The following is a description of a gene set: species: Homo sapiens Human Gene Set: GOBP_CENTRAL_NERVOUS_SYSTEM_DEVELOPMENT The process whose specific outcome is the progression of the central nervous system over time, from its formation to the mature structure. The central nervous system is the core nervous system that serves an integrating and coordinating function. In vertebrates it consists of the brain and spinal cord. In those invertebrates with a central nervous system it typically consists of a brain, cerebral ganglia and a nerve cord., and this is the list of marker genes: COL4A1, KCNC2, ABCB1, TP53, IMMP2L, NEUROD6, NKX6-2, MACO1, HSPG2, UCHL5, CXCL12, JRKL, PIAS4, VPS13B, ATIC, WDR1, P2RY12, NOTO, ATM, BRSK2, KIFBP, NOTCH1, PITX1, HIF1A, RRM1, MAPK1, KCNJ10, DHX37, HOOK3 (hook microtubule tethering protein 3), HPCAL4, ARL13B, BCAN, TCTN1, PADI2, CDK5R2, CDC42, EPHA5, NRG3, RBBP7, MGARP, VPS51, ODAD3, GPX4, PSEN1, FEZF2, KCNA1, VCX3A, MYRF, IL6ST, TBX20, NDNF, RAB18, FBXO41, HOXB1, HAPLN4, APP, PTCHD1, EED, PTPRJ, NR4A3, VPS54, GHRH, IFT122, RARA, SFRP2, ATG16L1, PTF1A, GLUD1, GPR37L1, GSN, SFRP1, BRINP2, ABAT, IL1RAPL2, TBR1, MARCKSL1, PLXNA1, CIC, BCL2, NOG, HTR6, HMX2, RECK, SKI, DAB1, BMPR1A (bone morphogenetic protein receptor type 1A), SRGAP2, VCAN, DPCD, PAX8, TAGLN3, EXT1, MEIS3P1, STK4, CD9, WDR89, FILIP1, SLC8A3, NKX2-1, CUL4B, ATRX, DCT, YWHAH, SEMA3F, BCL11B, BARHL2, FOXO3, GLI3, MCPH1, JHY, ERCC2, TUBB2B, EEF1AKMT4-ECE2, CWH43, C21orf91, LHX1, WNT4, SELENOP (selenoprotein P), SMO (NCBI Gene Id 6608), CASP3, CLUAP1, CASP5, EIF2B3, FGF13, ALDH1A3 (NCBI Gene Id 90476), VTN, ZEB1, ZIC4, ASPM (NCBI Gene Id 93990), SLC38A2, LHX5, NUMB, EIF2B4, SSTR1, RORB, CREB1, PRKG1, ISL2, ATP1A2, GRIN2B, ACTL6A, HAPLN2, FXR1, CEND1, SEMA6B, KDM1A, NRP1, GCM1, DRGX, SLC1A1, GPM6B, NEUROD4, IGF2BP1, INTU, SLIT3, CEP120, NTRK2, STAT3, S1PR1, TFAP2D, SUDS3, PALS1, JARID2, SIRT2, TMEM108, PRKCA, RAB3GAP1, GSC, MDGA1, GSX2, ARNT2, TOP2B, C12orf57 (NCBI Gene Id 113246), PAX2, EIF2B5, GLI1, CERS5, MAL, SLC6A3, DHX30, EPHB1, GRIK1, TPP1, FKRP, NCSTN, YWHAQ, TACC1, TBX19, DNAAF3, CHRNB2, PRKDC, GRIN1, WNT5A, NHEJ1, WWP1, SH3GL1, AKT3, NEUROG1, KCNE1, NME7, FOXG1, CDK5R1, LDLR, B2M, ARX, SPHK1, WDR37, KIF14, NDEL1, ADGRG6, SDF4, KIAA0319, RAC3, NLGN4X (NCBI Gene Id 64642), SLC25A46, STXBP3, ERBB4, LHX4 (LIM homeobox 4), LAMB2, ALDH1A2, TSPAN2, CNTN4, UQCRQ, ATN1, MAG, SEC16A, BAG3, ZIC2, CHST8, MEIS2, IRS2, ROBO2 (roundabout guidance receptor 2), FGF9, MDGA2, QKI, BMP2, TACC2, NSUN5, RAN, LIF, RFX4, SALL1, ZNF148, SOX4, SLC32A1, MIR26A1, LONRF2, ID2, PTBP2, NCAN, CNTF, CTNS (NCBI Gene Id 1497), PTCH1, FUT1, FOXB1, ISL1, NME5, BMP5, GRIA1, LHX8, PHOX2B, NKX2-6, NOVA2, BTD, TBX1, TAF1, FGFR1, POMGNT1, SYNE2, MYO16, TYROBP, PRKN, VPS4B, NDRG2, PHOX2A, BTG2, SLC2A1, CBLN1, GRID2, MAPKAP1, VIM, LRP6, FRS2, STK3, ITGB1, TP73, BBS1, EFHC1, TSKU, DAG1, CSNK2A2 (casein kinase 2 alpha 2), ZEB2, LMX1A, FGF10, OLIG1, CYP26B1, CALM2, COL3A1 (collagen type III alpha 1 chain), SLC6A4 (solute carrier family 6 member 4), COL2A1, EMX2, ATP5PF, POU6F1, SIX1 (NCBI Gene Id 6495), NPAS2, UFC1, SPTBN2, AIM2, CFL1, WNT7B, PTPN11, STIL, VIT, MYCN, HOXD10, LHX2, TMX2, LIG4, SOX1, FGF8, UGT8, SHANK3 (NCBI Gene Id 85358), PLXNB2 (plexin B2), MAOB, MAFB, DLG5, WNT7A, SUN2, DCX, KCNC1 (NCBI Gene Id 3746), DNAJC30, PTN, HOXA2 (homeobox A2), WDR62, BAG6, SOX13, ADARB1, GSX1, POU1F1, TREM2, ANP32B, OPHN1, DLX1, GBA1, CFAP43, APAF1, LMO4, CDK20, S100A1, MEIS1, LAMB1, CLN8, GRIN2D, NEFL, WNT9B, TRAPPC9, BMERB1, POU4F2, MDK, BIN1, ABCB6, EGFR, ERBB2, DKK1, SCN5A, FCGR2B, SEMA6D, PLXDC1, AGTPBP1, GPR158, CA10, RTN4RL1, CSF1R, LEF1, NNAT, FZD3, CCDC134, BMP7, AKNA, ZNF430, SNTG2, SMARCA1, NANOS1, RHEB, LAMC3, TOX, HOXB2, SOX2, WNT3A, NOTCH2NLA, TGIF1 (NCBI Gene Id 91941), SOS1, TULP3 (TUB like protein 3), ATF2, VAX2, HESX1, DCLK2, C5AR1, SH3GL3, ATRN, AARS1, FUT10, SPTBN4, ACAN, NRG1, GPR17, ACTB, NES, TFAP2A, ZIC5, TSC1, PCM1, DCLK1, TTC21B, H2BC12L, PPP1R9B (protein phosphatase 1 regulatory subunit 9B), SECISBP2, KNDC1, KLK6, AGTR2, SHROOM4, ENSG00000274276, S100A8 (S100 calcium binding protein A8), SPTBN1, EMX1, C3, GHRHR, ATXN1L, CENPF (NCBI Gene Id 51468), CSK, AQP1, SOX21, SMG9, PCDH9, DDIT4, ID3, NOTCH2NLB, UBE3A, HYDIN, INHBA, LRRK2, MAPK3, BCL6, PRMT5, ZIC1, LRP8, HAPLN1, GLI2 (NCBI Gene Id 50806), HDAC2, LEP, NPY, POU3F4, PAX5, CD3E, EZH1, ADORA2A, NHLH1, MBP, METTL3, SLC7A11, SLIT1, HPRT1, MNX1, NOTCH2NLC, DUSP15, IL6, ATXN1, SCYL2, VCX, NKX6-1, CERS1, MIOS, POU3F1, CRH, STK36, MARCKS, MXRA8, DLX2, LYN, COMT, SOX9, B4GALT5, DMBX1, ZSWIM6, FZD1, MKKS, PKD2, DLL1, UNC5D, KCNA2, VCY, PHLPP2, HERC1, MECP2, AGER, MAST1, SCRIB, FGF2, SETD1A (SET domain containing 1A, histone lysine methyltransferase, NCBI Gene Id 9739), KIF27, S100B, MBOAT7, LRP1, SRC, MYH10, ALDH5A1, ADAM22, HOXB8, DRD2, B4GALT2, SOCS7, LPAR1, NDST1, GABRB3, RERE, OTP (NCBI Gene Id 23440), NR0B1, MT-CO1, KRAS, CTNNB1, RTN1, BOK, GNB4, GAP43, SPG11, DUSP10, PLXNA3, RARB, GDNF, CDON, AKIRIN2, RAC1, PAK1, ZHX2, TAOK1, ARHGAP11B, PBX3, C1QA, KIRREL3, ARHGEF28, WDR47, TUBGCP2, TNFRSF21, TAL1, RTN4R, MATCAP1, WNT3, ABCA2, EN2, MINK1, FOXJ1, MIR181B1, ZNF488, NTRK3, SLC4A10, CNTN5, SPEF2 (NCBI Gene Id 80192), TTBK1, AGBL4, POMT2, NR1D1, EPHB3, PDGFC, TLX3, NEGR1, CYP26C1, EPHA4, RPS6KA3 (ribosomal protein S6 kinase A3), DAB2IP, TYRO3, NPAS1, DLL4, FGFR2, EPOR, POU3F3, MTF1, PLPP3, CORO1C, RPGRIP1L, GRIN2A, SEC24B, OLIG2, POU6F2, UBB, ELAVL4, GABRA4, ATP2B4, RTN4, TENM4, SOX11, AK8 (NCBI Gene Id 158067), GSTP1, TBX3, MYCBP2, SEMA5A, POMK, PAX4, EIF2B1, PEX13, RBBP4, NRP2, NDUFS4, SH3GL2, UFM1, GBX2, FOXR1, GART, UPF3B, NRXN1, PLP1, SHC3, DRAXIN, NDE1, FZD6, MPST, SEMA7A, GIGYF2, SYPL2, NCOA1, FOS, TGFBR2, DBX1, NARS1, SCT, DYNC2H1, ROR1, PEX5, TAL2, SLC6A17, XRCC1, VLDLR, FAT4 (NCBI Gene Id 79633), B4GALT6, APLP2, KDM6B, DRD1, PTS, GAS8 (growth arrest specific 8), INA, CDH2, SOX8, MEIS3 (Meis homeobox 3), BAX, ALDH3A2, DLX5, TPPP, PPT1, CNTN2, CYP26A1 (NCBI Gene Id 1592), LRP2, AVPR1A, HSD17B7, RYK, AATK, CAPG, MAPT, EML1, FOXC1, AMIGO2, SLC23A1, SUZ12, FOXP3, CCDC14, NEUROD2, NDN, BMP4, DSCAM, HMGA2 (NCBI Gene Id 8091), CNTN1, NFE2L1, WNT2B, DRD3, BBS2, INHBB, NUMBL, AXL, HTR5A, LDB1, OLIG3, CCKAR, UGP2, CTNNA2, HMX3, FZD4, TLR2, EFNA2, MAP1S, EOMES, APOD, IFT172, POTEE, TMEM98, SRD5A2, NFASC, YWHAE, SERPINE2, DMRTA2, TNFRSF1B, PAX6, MOG, AFF2, IFNG, ASCL1, TACC3, NAPA, PSMG1, TUBB2A, CXCR4, ZNF365, UNCX, WNT1, KIF26A, FAIM2, TRPC4, COX6B1, NCOR2, CDH1, THOC6, POU3F2, CELSR2, OGDH (NCBI Gene Id 4967), SKOR2, CKB, NR2E1, ODAD2, VPS13A, LHX6, DLC1, ATP5PB, FBXW11, TLR4, PITX3, CLP1, EPHA2, AVPR2, SMAD1, PGAP1, PTPRZ1, B3GLCT, EGF, G6PD, CDK5RAP1, CNTNAP1, ATAT1, CLCN2, IL34, SEZ6, GDF10, IER3IP1, MIR142, XRN2, LBX1, HOXB3, PBX4, DNER, OTX2, COQ8B, BRSK1, SEMA3E, NPFF, SHH, CNTN6, GSK3B, CALM3, TTPA, TTLL1, HOXC10, CCDC85C, ROBO1, TBC1D23, GBX1, PAFAH1B1, NHLH2, PCDH18, ADGRG1, HAPLN3, PTPRS, CDK5RAP2, VCX3B, PITPNM1, TNR, DIXDC1, QARS1, SOX15, GDF7, ANKLE2, WASF3, PRDM13, ZC4H2, ARHGAP35, TTC8, BBS4, GABRB1, ROGDI, ZPR1, GDF11, PHGDH, NDP, EFNA1, DYNLL1, GBA2, INTS15 (integrator complex subunit 15), IL1B, METTL14, PPP1R17, PHF8, CNTNAP2, CERS6, RTN3, F2, HAP1, UNC5C, RTN4RL2, CRK, SEMA3A, DNAJB1, OTX1, NDUFS3, FOXP2, MIR181C, PSPN, ANAPC7, EPHA7 (NCBI Gene Id 2045), HNRNPD, CITED2, VCX2, CSNK1D, ECRG4, MYD88, ACKR3, CHD7, EIF2B2, TGIF2, DOCK7, SRSF1, FKTN, CNP, FOXP1, NR3C1, DMRT3, SOX12, LARGE1, FBXO45, PAX7, PTEN, SYNGR3, MIB1, BRCA2, PROX1, NGFR, MACROD2 (NCBI Gene Id 284776), XAB2, GLIS2, SCYL1, NCOA6, MTOR, RHOA, AMIGO1, BCR, S100A9, CEP290, BMI1, CHD5, CRKL, GIT2, BARHL1, NAV2, PDSS2, DCTN1, FA2H, ZDHHC16, FEZ1, RTN2, GRHL2, NIPBL, FPR2, MACROH2A2, KDM4B, NF1, NR2F2, NAGLU, ZNF335, SOX10, MFSD2A, RORA, COX7B, SOX3, ARCN1, PIANP, VAX1, BRINP3 (BMP/retinoic acid inducible neural specific 3), SRF, B3GNT5, BLOC1S6 (NCBI Gene Id 26258), AMIGO3, EZH2 (NCBI Gene Id 392834), MSX1, CDK6, NRROS, NEUROG3, CCDC39, RPS6KA6, LOXL3, NKX2-2, SERPINI1, GRIN2C, GRHL3, EPHB2, AFG2A, NEUROD1, CALM1, CHD8, ALK, HES1, CELSR1, TUBA1A, SCYL3, BTBD3, EGR2, BMPR1B, RNF103, NEUROG2, SLITRK5, FOXN4, GATA2, SIN3A, TNF, NR4A2, SLIT2, NRCAM, CLN5, DNAH5, RBPJ, FEZF1, SLC1A2, CLDN3, CCDC141, MFSD8, ADGRA2, HDAC1, SSBP3, ID4, HNF1B, ARL6, PLXNA4, MNAT1, BGLAP, APLP1, MT-ND4, E2F1, HSPA5, PITX2, FLNA, ELP3, CDKN2C, VCY1B, HES5, BASP1, TTBK2, CBS, ADAM23, C2CD3, ABT1, DAAM2, NIN, IFT80, CRTAC1, SEMA4C, PLCB1 (NCBI Gene Id 23236), AHI1, DRP2, BPGM, VSTM5, HTRA2, ATP1B2, PBX2, GRN, PYGO2, VSX2, SRGAP2C, ZIC3, MED1, RAD1, HELT, KAT2A, NRGN, NCKAP1, EN1, SCN1B, MAP2K1 (mitogen-activated protein kinase kinase 1), IGF1, KDM2B, TFAP2C, TRNP1, NODAL, SUFU, GFAP, MSI1, SPOCK1, SIX3, CDH11 (cadherin 11), WLS, LHX3, UTP3, RAX, GMPPA, TMEM14B, MSI2, TRA2B, SCIN, ATF5, CHRD, SPHK2 (NCBI Gene Id 56848), NMUR2, SOX6, ATP6AP2, DISC1, SHROOM2, PHACTR1, PLXNA2, CDK5RAP3, TGFB1, WNT2, GIT1, TWSG1, MED12, RAPGEF2, ATOH1, OPALIN, KDM7A, MAP2, CDK5, CMA1, DSCAML1, BRINP1, KLHL1 (kelch like family member 1), PRDM8 (NCBI Gene Id 56978), CLCF1, ODAD4, ZBTB16, CITED1, RELN, SOX14, IFNGR1, PROP1, DCC, CX3CR1, NPTX1, ITGAM, FYN, FXR2, ZMIZ1, NOTCH3, SRD5A1, NFIB, GNPAT, LRP5, SZT2, BBS7, FANCD2, BPTF, BNIP3, CLU, LSR, ATP7A, ABL1, SLC45A3, SUN1, TTC36, PKD1, NF2, LDHA, WHRN, PBX1, POU4F1 (NCBI Gene Id 730659)